Given this list of marker genes Gngt1, Gng10, Gng8, Gabrb3, Gng7, Gabrr1, Gabrq, Gnat3, Gnai1, Gngt2, Kcnj2, Adcy7 (NCBI Gene Id 11513), Gabrr3, Kcnj12, Gng3, Gng4, Gnb2, Gng5, Gnb3, Gng11, Gabra6, Kcnj10, Kcnj5, Gabbr1, Adcy8, Gabra4, Gabrr2, Gabra3, Adcy5, Gnb5, Kcnj3, Gabra1, here is a description of the gene set: This event has been computationally inferred from an event that has been demonstrated in another species.<p>The inference is based on the homology mapping from PANTHER. Briefly, reactions for which all involved PhysicalEntities (in input, output and catalyst) have a mapped orthologue/paralogue (for complexes at least 75% of components must have a mapping) are inferred to the other species. studied in species Mus musculus part of: Neurotransmitter receptors and postsynaptic signal transmission Reactome Pathway: GABA receptor activation electronically inferred by orthology from the curated human pathway